Given this list of marker genes Stx12, Bloc1s4, Bloc1s6, Washc4, Bloc1s3, Snap25, Bloc1s2, Bloc1s1, Pi4k2a, Washc1, Kxd1, Snapin, Snap47, Bloc1s5, Dtnbp1, here is a description of the gene set: Mouse Gene Set: GOCC_BLOC_1_COMPLEX A protein complex required for the biogenesis of specialized organelles of the endosomal-lysosomal system, such as melanosomes and platelet dense granules. Many of the protein subunits are conserved between mouse and human; the mouse complex contains the Pallidin, Muted, Cappuccino, Dysbindin, Snapin, BLOS1, BLOS2, AND BLOS3 proteins. species: Mus musculus